Given this list of marker genes MAPK14 (mitogen-activated protein kinase 14), TSC2, CREB1, YWHAH, YWHAB, ETV1, HSPB1, TCF3, YWHAG, CDC25B, MAPKAPK2, YWHAE, MAPKAPK3, TH, YWHAQ, SRF, RAF1 (NCBI Gene Id 5894), LSP1, SFN (stratifin), MAPK11, YWHAZ, here is a description of the gene set: species: Homo sapiens Human Gene Set: PID_P38_MK2_PATHWAY p38 signaling mediated by MAPKAP kinases from publication Schaefer CF, Anthony K, Krupa S, Buchoff J, Day M, Hannay T, Buetow KH (PMID 18832364)